The following is a description of a gene set: species: Homo sapiens Human Gene Set: HAY_BONE_MARROW_CD34_POS_LMPP from publication Hay SB, Ferchen K, Chetal K, Grimes HL, Salomonis N (PMID 30243574), and this is the list of marker genes: NEGR1, NPTX2, CRMA, PRSS2, ACY3, SDK2, NREP, TRH